Given this list of marker genes MIA2, BMP8A, NDUFAF4, HAUS8 (HAUS augmin like complex subunit 8), PPP2R5C, NGEF, RSPH9, SLC43A2, KNOP1, ATPAF1, FCER2, SUCLG2, GPR25, AZI2, ZNF362, NAA38, CHIC1, GCNT1, ENO1, HLX, OXR1, TRIR, AGPAT2, BEND4, ABHD1, EIF4E3, TBC1D4, MBIP, ZNF175, PTPRC, G6PD, UBE2D3 (ubiquitin conjugating enzyme E2 D3), BCL2L12, CEP95, PLEKHM3, GK, CNPY3, CTSD, NFATC3, SSRP1 (structure specific recognition protein 1), ARHGAP1, HERC2, ERI2, WRN, AGPS, MTRR, RAB37, KIAA0930, RRM2B, KRT80, RUNX3, SNTA1, CUL3, NCOA2, ZFP36L2, SLC15A2, NAT8L, MAPK1, SPN, ERMP1, MRPL33, GALNT1, RAPGEF1, AZIN1, ZWILCH, SMPD2, GPR155, FREY1, TMEM131, DENND4C, ZFP41, MAPK3, TNRC6B, TNFRSF1B, ETNK1, PDE6D, SRRM1, KPTN, TSC22D3, COL17A1, NEB, PLXNB2, SLC6A12, NRROS, LMO2, HRH1, HEATR5A, IFT140, ACVR1B, TRPT1, IDS, FABP1, LAPTM5, TACC1, SLC30A6, DENND1C, STAG1, H2AJ, TMEM74, DMAC2, PARP14, INO80E, PDXK, NOL7, RAP1A, SALL4, DNAJC22, HVCN1, CD79B, PGM2 (NCBI Gene Id 55276), LPL, ZNF14, SLC38A2, CAST, TREML1, WDR13 (WD repeat domain 13), GLE1 (GLE1 RNA export mediator), RIPOR2, SMG1, GIMAP4, BLTP3B, EED, GBA2, PNKP, GPRASP3, FXYD2, ITGB3, NRIP1, ZMIZ2, TNFRSF18, P2RY10, SMAD1, STK40, ZSCAN22, EIF3F, ADGRE5, STIL, PRG2, B4GALNT2, RASAL2, PHLPP2, DKK2, HMG20A, RHOG, EFCAB14, IKZF1, NFAT5, CSRNP1, SLAMF6, AEBP2, NCOA1, TXNDC12, ECPAS, BBS9, ZFP90, F9, RTN4RL1, PTPN12, PGGHG, RAP2B, ST3GAL2, BMPR2, MED11, CCDC47, SESN3, TNIK, S100PBP, AHRR, SLC45A4, STAG2, STARD9, CDKN1B, ENC1, PRKDC, FASLG, USP27X, WDR20, C1QC, TBX6, MND1, SMAD7, PRC1, GJC2, SHLD1, SCN2B, GPR68, OGFRL1, IFI30, CLEC6A, MYO9B, LCP1, MKRN1 (NCBI Gene Id 392799), IFIH1, CBFA2T2, PAIP2, KLF13, PSPC1, BUB1B, ALAS1 (NCBI Gene Id 211), FAM120B, here is a description of the gene set: Th1 and Th2 cells arise from a common precursor cell in response to triggering through the TCR and cytokine receptors for IL-12 or IL-4. This leads to activation of complex signaling pathways, which are not known in detail. Disturbances in the balance between type 1 and type 2 responses can lead to certain immune-mediated diseases. Thus, it is important to understand how Th1 and Th2 cells are generated. To clarify the mechanisms as to how IL-12 and IL-4 induce Th1 and Th2 differentiation and how TGF-beta can inhibit this process, we have used oligonucleotide arrays to examine the early polarization of Th1 and Th2 cells in the presence and absence of TGF-beta after 0, 2, 6 and 48 hours of polarization. from publication Lund R, Aittokallio T, Nevalainen O, Lahesmaa R (PMID 14607935) species: Homo sapiens Human Gene Set: GSE2770_UNTREATED_VS_IL12_TREATED_ACT_CD4_TCELL_48H_UP Genes up-regulated in CD4 T cells: untreated (0h) versus activated by anti-CD3 and anti-CD28 and then stimulated by IL-12 (48h).